Given this list of marker genes SLC39A4, here is a description of the gene set: Reactome Pathway: Defective SLC39A4 causes acrodermatitis enteropathica, zinc-deficiency type (AEZ) part of: SLC transporter disorders SLC39A4 encodes the human zinc transporter hZIP4 which plays an important role in cellular zinc homeostasis. Defects in SLC39A4 result in the inherited condition acrodermatitis enteropathica, zinc deficiency type (AEZ; MIM:201100), caused by the inability to absorb dietary zinc from the duodenum and jejunum. Clinical features include growth retardation, immune system dysfunction, severe dermatitis and mental disorders. studied in species Homo sapiens